Given this list of marker genes TMCO6, CKB, RMND1, ZNF614, PAQR4, RBM25, THRA, UBFD1 (ubiquitin family domain containing 1), GOSR2 (golgi SNAP receptor complex member 2), RBMS1, LCN2, ERN1, ZNRD2, MACROH2A1, WIZ, MICA, PAFAH1B2, EFNA5, PSIP1 (NCBI Gene Id 93428), NCOR1, ADM, SLC24A3, ANK1, PSAP, ZNF91, SH3BGR, TRGC1, NMU, RNASE2, TAC3, IQCK, DST, ZC2HC1A, CYP2E1, ACYP2, ARG2, LGALS1, CEBPG, CIR1, HTR4, C1orf54, MXRA8, VWF, ARL17A, AP5S1, ZNF571, KCNN1, CIAO1, GSTM4, A1CF, AHSA2P, AIF1, WEE1, RPS4XP9, CD44, MAP7, GPR153, CELSR2, TMEM254 (NCBI Gene Id 80195), SMIM27, PNPLA4, SCMH1, NUDT2, F13A1, ZNF33B, BRD2, ZNF473, NT5M, ARR3, SRR, CYP1A2, NDE1, KIZ, PDXK, TMPRSS6, COL2A1, TNFRSF25, ELANE, MTERF4, C10orf88, RAD1, PSG9, ITGA4, TREX1, RPS6KA2, RET, UPF1, ICA1, ZNF394, IL27RA, PHF8, MX2, ATP8B1, CAMKK2, ALOX12, NOTCH2, ORAI2, MAX, SUN1, TADA2A, FKBP11, PPIAP21 (NCBI Gene Id 170536), EDAR, SDHAF1, RPS20P22, ZNF318, TOR1AIP1, ZNF250, DTWD1, TBC1D9B, NCKAP1L, HEMK1, IGLL1, MTHFS, LPIN2, AHCTF1, XRCC4, RASGRP2, SKAP2, ANXA3, CMAHP, GAS7, CFLAR, ZNF451, NOCT, DAO, RNASE3, PSRC1, BLOC1S1, FAM30A, TSR1, KANK1, H2AC6, KCTD15, SRPK2, LONP2, RAPGEF2, FEM1B, CDV3, MAGT1, CANX, H4C5, RIPOR2, NAGA, MR1, FAM13A, C6orf62, SENP2, WNK1, RANBP17, TMEM160, GBF1, REX1BD, RPL18AP16, MID2, BCAT2, ADAM22, BRCA2, MXD4, ZDHHC18, ZNF232, RAB27A, DDX39B, HFE (NCBI Gene Id 3077), WWC1, MTAP, REG3A (regenerating family member 3 alpha), PGM3, IFT27, HPS4, MS4A2, AP4S1, DSTNP2, CDC27, SLC7A8, NCOR2, TRIB3, SEPTIN6, MTMR12, NUDT6, NQO1, RPL29P5, TPD52 (tumor protein D52), ACTR2, TBC1D8, TRAF3IP3, AZI2, MYB, CUL5, C1orf50, ABCA5, TAF12, NTHL1, SLC27A3, CDKN2B-AS1, RFC5, OBSL1, GALT, H2AC8, PLEKHA8P1, GSN, CLCN7, PHKA2, SUMO3, SUPT7L, DCTN4, KDM4B, ALOX5AP, TCF3, ITPKC (NCBI Gene Id 80271), METTL2B, H2BC9, ARFRP1, RPS3AP5, CLDN10, IRGQ, MPO, MAGOH2P, ERAP1, NUDT3, GLTP, TUBAL3, BAX, TMEM8B, NME5 (NCBI Gene Id 8382), PCGF2 (polycomb group ring finger 2), RNASE2CP, RHOBTB1, GID4, PAM16, KLHL20 (kelch like family member 20), RNF40, RPL35P8, TSPAN5, CHST5, SPATA7, SFI1, NOPCHAP1, APOM, OBI1, SMAD3, NDRG3, RC3H2, PPBP, SSBP2, POLD2, APOLD1, PIK3R3, PPP1R12A, MAPKAPK2, RRBP1, NNT, NFYA, ENDOD1 (NCBI Gene Id 23052), EIF3M, RSRC1, PCIF1, WDR45 (WD repeat domain 45), SMG7, SUPT6H, ZNF16, ACSM3, PITPNC1, ZNF142, TMEM134, RPAP1, TAF1A, DNASE1L1, ZNF74, TMSB15A, AURKB, DTX4 (NCBI Gene Id 23220), MED22, ZMYM4, PGLS, CPA2, CLN5, SPTBN1, HYI, SLC11A1, ENPP4, SDAD1, ZNF492, UBE2D4, CAPZB, TOGARAM1, ZNF93, RHOB, UTP20, PURA, LMCD1, IKBKE, RDX, ASMTL, GNA11, CYFIP2, INSIG1, HSPD1, RPL10L, TPM4, CPT1A, MYCT1, MYO9B, PLEKHM1, BICD1, ZNF133, TNFRSF14, KRIT1, CST7, H2BC7, SAP30L, MXD1, LMBR1L, TMPRSS15, HSPA9, HMGB3P1, ACACB, ISG15, SEL1L3, FMO5, DIS3, ZNF117, ATPAF2, TAX1BP1, HEATR3, OR1F1, DPH5, FAM174C, TMEM120B, SLC39A4, H2BC6, RAB4A, DCTN3, ARHGEF10, DIAPH2, FBXO9, POLR2D, TWF2 (twinfilin actin binding protein 2), LYRM2, GIMAP5, GGA3, BNIP3, ST3GAL2, RPL7P27 (ribosomal protein L7 pseudogene 27), INF2, SECISBP2L, THAP4, MMRN1, ADAMTS12, ARL4D, RPL12P11, RPS28, PEA15, ELOVL5, SCYL3, SGF29, RPL23AP1, MYLIP, ZNF248, PEX1, RPL28, MYO15B (NCBI Gene Id 85386), MSH5, CCDC28B, PTCRA, ZNF32, GADD45G (NCBI Gene Id 23575), FBXL4, ZCCHC24, BTD, HNRNPM, BPHL, CASP4, COL8A2, EFNB3, SNHG3, LAMTOR2, ATG5, POLR2F, PSPH, HMCES, CAPN3, WARS2, SLC35A3, RECQL, PPIP5K1, SNHG20, FLII, UNC5B, AHR, DDIT3, BMP7, DCLRE1C, XRCC2, TENT4A (NCBI Gene Id 11044), CYTH2, NR2C1, RMND5B, USE1, MRPL23, CLEC1B, YPEL1, ZFYVE26, H2BC12L, POM121, PRG2, EFCAB2, MFN2 (NCBI Gene Id 9927), AOAH, MAOA (NCBI Gene Id 441491), CLASRP, ZHX3, ACP5, CTSG, ZNF589, PTH2R, HMBS (NCBI Gene Id 5448), SIVA1, DNAJC16, LGALS8, SYNE3, MID1, BBLN, ZNF43, H1-2, ZNF669, ECPAS, H2BC5, OSTF1, SGSM2, DCUN1D2, CDC5L (NCBI Gene Id 988), DALRD3, CDKN1C, EPHB4, DESI1, TRIOBP, EML3, ARIH2, CTSK, DMBT1, PIGN, UGGT2, PLK1, CTSB, TRIM52, BTG1, CIDEB, TADA3, ARNT, AHDC1, KIF22, MPG, DBR1, GPR12, GLP1R, OSGIN2, TBXA2R, CDC42, RARS1, DOCK1, IL10RB, MED14, HK1, GRK4, DCAF10, ZNF177, NME3, MAP4, PNO1, here is a description of the gene set: Human Gene Set: GAZDA_DIAMOND_BLACKFAN_ANEMIA_ERYTHROID_DN Diamond-Blackfan anemia (DBA) is a broad developmental disease characterized by anemia, bone marrow (BM) erythroblastopenia, and an increased incidence of malignancy. Mutations in ribosomal protein gene S19 (RPS19) are found in approximately 25% of DBA patients; however, the role of RPS19 in the pathogenesis of DBA remains unknown. Using global gene expression analysis, we compared highly purified multipotential, erythroid, and myeloid BM progenitors from RPS19 mutated and control individuals. We found several ribosomal protein genes downregulated in all DBA progenitors. Apoptosis genes, such as TNFRSF10B and FAS, transcriptional control genes, including the erythropoietic transcription factor MYB (encoding c-myb), and translational genes were greatly dysregulated, mostly in diseased erythroid cells. Cancer-related genes, including RAS family oncogenes and tumor suppressor genes, were significantly dysregulated in all diseased progenitors. In addition, our results provide evidence that RPS19 mutations lead to codownregulation of multiple ribosomal protein genes, as well as downregulation of genes involved in translation in DBA cells. In conclusion, the altered expression of cancer-related genes suggests a molecular basis for malignancy in DBA. Downregulation of c-myb expression, which causes complete failure of fetal liver erythropoiesis in knockout mice, suggests a link between RPS19 mutations and reduced erythropoiesis in DBA. studied in species Homo sapiens Genes down-regulated in erythroid progenitor cells isolated from bone marrow of patients with Diamond-Blackfan anemia (DBA) and mutated RPS19. from publication Gazda HT, Kho AT, Sanoudou D, Zaucha JM, Kohane IS, Sieff CA, Beggs AH (PMID 16741228)